The following is a description of a gene set: species: Homo sapiens from publication Fontaine JF, Mirebeau-Prunier D, Franc B, Triau S, Rodien P, Houlgatte R, Malthièry Y, Savagner F (PMID 17968324) Conventional histology failed to classify part of non-medullary thyroid lesions as either benign or malignant. The group of tumours of uncertain malignancy (T-UM) concerns either atypical follicular adenomas or the recently called 'tumours of uncertain malignant potential'. To refine this classification we analysed microarray data from 93 follicular thyroid tumours: 10 T-UM, 3 follicular carcinomas, 13 papillary thyroid carcinomas and 67 follicular adenomas, compared to 73 control thyroid tissue samples. The diagnosis potential of 16 selected genes was validated by real-time quantitative RT-PCR on 6 additional T-UM. The gene expression profiles in several groups were examined with reference to the mutational status of the RET/PTC, BRAF and RAS genes. A pathological score (histological and immunohistochemical) was estimate for each of the T-UM involved in the study. The correlation between the T-UM gene profiles and the pathological score allowed a separation of the samples in two groups of benign or malignant tumours. Our analysis confirms the heterogeneity of T-UM and highlighted the molecular similarities between some cases and true carcinomas. We demonstrated the ability of few marker genes to serve as diagnosis tools and the need of a T-UM pathological scoring. Human Gene Set: FONTAINE_PAPILLARY_THYROID_CARCINOMA_UP Genes up-regulated in papillary thyroid carcinoma (PTC) compared to other thyroid tumors., and this is the list of marker genes: SLC22A18, ADRB3, CD4, KLF4, SPACA6, FAM107A, SNCB, DPP4, PRKG1, NIPAL3, S100A10, KRT18, CD63, CCND3, SPP1, NACC1, HCLS1, TENM1, SLPI, MLLT1, TMEM45B, NOTCH1, ECM1, CA11, CAPN3, CITED1, CLHC1, LGALS3BP, SENP6, FMO5, LMO3, CCNE1, ZNF217, ILF2, GATB, NELFA, PDLIM1, CD47, HSPB7, TESC, KPNA2, RBBP4, PLXNB2, KCNK5, ARMCX3, SNRPG, IL19, PDCD4, VCL, ABCC3, VTI1A, SCEL, CTNNA1, COX15, CLDN1, PITPNA, TEX13A, FUS, CDH3, IGF2BP2, S100A6, CTTN, ETV4, SHE, RPS6KA2, PSAT1